The following is a description of a gene set: species: Mus musculus Mouse Gene Set: REACTOME_CELLULAR_HEXOSE_TRANSPORT Cellular hexose transport, and this is the list of marker genes: Slc2a8, Slc2a2, Slc2a1, Slc50a1, Fgf21, Slc5a4a, Slc2a4, Slc45a3, Slc2a9, Mfsd4b4, Slc2a10, Slc5a1, Slc2a6, Slc5a9, Slc2a12, Slc5a10, Slc5a2, Slc2a3, Slc2a7 (solute carrier family 2 (facilitated glucose transporter), member 7)